Given this list of marker genes EIF3A, EIF3L, EIF3D, EIF3G, EIF3B, here is a description of the gene set: studied in species Homo sapiens Human Gene Set: GOBP_VIRAL_TRANSLATIONAL_TERMINATION_REINITIATION A process which occurs as part of viral mRNA translation which allows expression of a downstream open reading frame (ORF) in a dicistronic mRNA. In this process, ribosomes translate the upstream ORF but following termination, a proportion of 40S subunits remain tethered to the mRNA and go on to re-initiate translation at the start codon of the downstream ORF.